Given this list of marker genes Ep300, Fosl2, Dock2, Stat3, Myb, Ptpn22, Jak3, Ncor1, Sash3, Ap3b1, Pla2g2d, Rc3h2, Cd300a, Hsph1, H2-M3, Ndfip1, Cd83, Spn, Tcirg1, Cbfb, Gata3, Cd244a, Il2ra, Nlrp3, Xcl1, Dapl1, Lef1, Crtam, Pax1, Myc, Abl2 (ABL proto-oncogene 2, non-receptor tyrosine kinase), Tgfb1, Atf2, Ihh, Ccr7, Zfp35, Ccr6, Prr7, Elf4, Gimap1, Ccl20, Abl1, Rora, Rhoa, Ctsl (NCBI Gene Id 320361), Irf4, Batf, Cd55, Gpr183, Mir301, Ins2, Bcl2, Il21, Gimap3, Nfkbid, Mapk8ip1, Clec4a4, Mir326, Jak2, Il12a, Rorc, Cd3e, Lilrb4b, Il2rg, Zap70, Braf, Ager, Btla (B and T lymphocyte associated), Arg2, Gpr18, Nckap1l, Kcnk18, Hlx, Stat4, Klhl25, Foxp3, Tnfsf4, Nkap, Lgals9, Tbx21, Nkx2-3, Il27, Prdm1, Clec4a2, Brd4, Mir873a, Ripk2, H2-T23, Bcl11b, Itk, Clec4f, Nfkbiz, Shh, Tbk1, Psmb11, Pik3r1, Syk, Tnfsf8, Il4, Prkcq, Lilrb4a, Brd2, Rc3h1, Ptger4, Slamf6, Il23a, Smad7, Tnfrsf14, Psap, Il18, Ptprc (NCBI Gene Id 19264), Ccl19, Tmem98, Kmt2a, Pnp, Cd24a, Ap3d1, Wdfy4, Socs5, Relb, Tcf7, Ascl2, Mtor, Lgals1, Clec4g, Ptcra, Abcc1, Shb (src homology 2 domain-containing transforming protein B), Cd69, Zbtb7b, Rasal3, Foxp1, Kctd9, Itpkb, Hfe, Bcl3, Irf1, Il15 (NCBI Gene Id 16168), Malt1, Clec4a3, Rpl22, Cebpb, Hmgb1, Zc3h12a, Il4ra, Igtp, H2-Ea, Txk, Gimap5 (NCBI Gene Id 319541), Cd55b, Adora2a, Fut7, Atp7a, Bcl6, Il2, Tox, Cdh26, Armc5, Pf4 (NCBI Gene Id 56744), Men1, Tnfsf18, Opa1, Blm, Itch, Card11, Cblb, Entpd7, Eomes, Tgfbr2, Socs1, Tyk2, Twsg1, Nkg7, Ly9, Traj18, Slc4a2, Il18r1, Ankle1, Vsir, Cd1d2, Cd80, Stoml2, Gli3, Cd44, Rara, Satb1, Prkcz, Runx3, Stat6, Il12b, Anxa1, Il6, Cd81, Zfp683, Bag6 (BCL2-associated athanogene 6), Ada, Cracr2a, Il6ra, Gadd45g (growth arrest and DNA-damage-inducible 45 gamma), Rsad2, Cd28, Sema4a, Otud5, Cd160, Cd1d1, Ifng, Runx1, Ccr2, Cd274, Ins1 (insulin I), Tarm1, Irgm1, Sh3rf1, Loxl3, here is a description of the gene set: species: Mus musculus The change in morphology and behavior of an alpha-beta T cell resulting from exposure to a mitogen, cytokine, chemokine, cellular ligand, or an antigen for which it is specific. Mouse Gene Set: GOBP_ALPHA_BETA_T_CELL_ACTIVATION